Given this list of marker genes RABL2A, DEFB4A, UBE2E1, GPR15, EXOSC9, ZBTB5, PKD1L2, NXPE2, ZNF830, ADAMTS6, LIPT2, FOXF2, CDH2, TMEM204 (transmembrane protein 204), UBA3, MYOM1, KCTD1, NADSYN1, CABS1, C12orf50, MYL10, DMKN, CDKL1, EIF1, ATP5F1B, KDM5A, GDI2, CACNB1, ALDH1B1, GPR19, IZUMO2, TLNRD1 (NCBI Gene Id 59274), GAST, CCDC117, CCT4, AXDND1, CNKSR2, SNTG1, SCARNA13 (small Cajal body-specific RNA 13), HSD17B8, PIGN, ZNF800 (NCBI Gene Id 168850), PAWR, CHRM4, FREY1, FLI1, CACNB3, CD53, FTL, PIH1D2, PNPO, RB1, VSNL1, MMP17, FUNDC1, CCNC, HOXD1, CRBN, TANGO6, SLC16A4, MRM2, ASXL2, PTX3, SLC6A1, TPT1, TOMM20, PRICKLE3, NLRP4, IL13RA2, SUMF2, PRKAA1, LRGUK, CD320, RAB5A, TRMT9B (NCBI Gene Id 57604), ABI1, CA4, PROX2, FGF21, DOCK4, GABRA2, XKR8, KIAA0825, SNRNP40, RAB30, UBE2D2, CRABP1, TSPAN7, SCOC, SEMA5A, SLC36A2, CD27-AS1, CGREF1, STYX, BECN1, DR1, NPY1R, GIPC3, PWWP4, SRP68, TUBE1, INPP4B, PLD6, PRKAA2, ICA1, KRT8, TEX12, ALOX15, ZBTB44, MRO, TMIGD1, GZMM, ZNF600, ACO1, HIPK3, POLR3H, YPEL1, LRRC69, RSPH4A, TDO2, CIDEA, MTFR1, EEF1A2, DPH7, IRX3, CCDC81, PLIN5, LRIF1, TCF15, DIDO1, KRT1, UNC79, FUCA2, PCBP1, FBXL5, TMEM200A, SCNN1G, CDH15, MORF4L2, YTHDC1, CNTNAP2, RPL19, KRIT1, ZNF347, RBM7, ATP1A2, SH3BGRL, PLA2G4E, PDILT, ATP5PB, PCYT1B, RASL12, EMCN, TNRC6B, DNAJB9, RAP1B, NTN4, HOXB9, WDPCP, PABPC1L, ZCCHC14 (zinc finger CCHC-type containing 14), C11orf65, CRYBB2, LINS1, NAP1L2, PRSS23, SEZ6L2, GLRX3, RASL11B (RAS like family 11 member B), WSB1, ARPC5, NDFIP1, ACBD5, LYPLA1, CCDC68, TG, RINT1, CEP68, SERBP1, PEX12, CHRNG, GOLPH3, FAM204A, TMEM64, SYAP1, LRIT2 (NCBI Gene Id 340745), PCDHB15, OR2S2, CHM, STK4, SORBS1, ECEL1, MMUT, GPR75, EIF4G2, MYL1, SIT1, OPN4, RFTN2, PLEKHA3, here is a description of the gene set: Genes down-regulated in B lymphocytes with MAP3K7 knockout: untreated versus anti IgM for 1h. The activation signaling of transcription factor nuclear factor-kB (NF-kB) plays central role for immune system. One of key kinase mediating this pathway is TAK1 in adaptive and innate immunity. However, role of TAK1 in B cell receptor signaling is still unclear. To know effects of TAK1-deletion on the gene expression induced by anti-IgM, we performed the time course analysis in comparison of wild type with TAK1-deleted splenic B cells. Human Gene Set: GSE41176_UNSTIM_VS_ANTI_IGM_STIM_TAK1_KO_BCELL_1H_DN from publication Shinohara H, Behar M, Inoue K, Hiroshima M, Yasuda T, Nagashima T, Kimura S, Sanjo H, Maeda S, Yumoto N, Ki S, Akira S, Sako Y, Hoffmann A, Kurosaki T, Okada-Hatakeyama M (PMID 24833394) studied in species Homo sapiens